Given this list of marker genes TIMP1, RECK (reversion inducing cysteine rich protein with kazal motifs), MBP, SVBP, TIMP2, here is a description of the gene set: species: Homo sapiens Any process that modulates the frequency, rate or extent of metallopeptidase activity. Human Gene Set: GOBP_REGULATION_OF_METALLOPEPTIDASE_ACTIVITY